Given this list of marker genes APOD, ACTG2, TNS3, KRT17, FHOD3, AQP3 (aquaporin 3 (Gill blood group)), CALD1, SPANXA1, FBN2 (fibrillin 2), EFEMP1, SNAI2, NT5E, L1CAM, ITGB6, CCN5, PCSK2, EPAS1, CCN2, TAGLN, FHL2, here is a description of the gene set: Human Gene Set: MASRI_RESISTANCE_TO_TAMOXIFEN_AND_AROMATASE_INHIBITORS_DN studied in species Homo sapiens Genes down-regulated in derivatives of MCF-7aro cells (breast cancer) that developed resistance to tamoxifen or inhibitors of aromatase (CYP19A1). Acquired resistance to either tamoxifen or aromatase inhibitors (AI) develops after prolonged treatment in a majority of hormone-responsive breast cancers. In an attempt to further elucidate mechanisms of acquired resistance to AIs, MCF-7aro cells resistant to letrozole (T+LET R), anastrozole (T+ANA R), and exemestane (T+EXE R), as well as long-term estrogen deprived (LTEDaro) and tamoxifen-resistant (T+TAM R) lines were generated. This is the first complete panel of endocrine therapy-resistant cell lines, which were generated as multiple independent biological replicates for unbiased genome-wide analysis using affymetrix microarrays. Although similarities are apparent, microarray results clearly show gene signatures unique to AI-resistance were inherently different from LTEDaro and T+TAM R gene expression profiles. Based on hierarchical clustering, unique estrogen-responsive gene signatures vary depending on cell line, with some genes up-regulated in all lines versus other genes up-regulated only in the AI-resistant lines. Characterization of these resistant lines showed that LTEDaro, T+LET R, and T+ANA R cells contained a constitutively active estrogen receptor (ER)alpha that does not require estrogen for activation. This ligand-independent activation of ER was not observed in the parental cells, as well as T+EXE R and T+TAM R cells. Further characterization of these resistant lines was performed using cell cycle analysis, immunofluorescence experiments to visualize ER subcellular localization, as well as cross-resistance studies to determine second-line inhibitor response. Using this well-defined model system, our studies provide important information regarding differences in resistance mechanisms to AIs, TAM, and LTEDaro, which are critical in overcoming resistance when treating hormone-responsive breast cancers. from publication Masri S, Phung S, Wang X, Wu X, Yuan YC, Wagman L, Chen S (PMID 18559539)